The following is a description of a gene set: Human Gene Set: HP_ADVANCED_ERUPTION_OF_TEETH Premature tooth eruption, which can be defined as tooth eruption more than 2 SD earlier than the mean eruption age. Advanced eruption of teeth studied in species Homo sapiens, and this is the list of marker genes: VARS1, LMNA, KRT6B, SPECC1L, POLR3A, NEK1, DHCR7, BCL11B, EHMT1, ZMPSTE24, FAM20C, FGFR2, ZSWIM6, GLI3, GTF2H5, DSP, EP300, CEP120, BMP4, INSR, KDM6A, JUP, KRT17, AMER1, C2CD3, POLR3B, KRT16, NFIX, CILK1, DPH1, NSD1, RPS6KA3, KMT2D, FLNA, KRT6A, ADNP, INTU, KDF1, CHD6, PTH1R, MID1, CREBBP, EVC, KMT2C, EVC2, MKS1